The following is a description of a gene set: Human Gene Set: REACTOME_INTERLEUKIN_3_INTERLEUKIN_5_AND_GM_CSF_SIGNALING species: Homo sapiens Interleukin-3, Interleukin-5 and GM-CSF signaling, and this is the list of marker genes: CSF2RA, PIK3R3, PTPN11, RAPGEF1, TEC, VAV1, JAK3, YWHAZ, CRK, INPP5D, UBB, PIK3R2, IL3RA, SYK, IL5RA, PRKACA, CSF2, STAT5A, CSF2RB, SOS1, STAT5B, PIK3CB, HCK, INPPL1, SHC1, IL3, UBA52, IL2, LYN, IL2RA, GAB2, IL5, PIK3CD, FYN, JAK1, BLNK, YES1, UBC, GRB2, RPS27A, JAK2, IL2RG (NCBI Gene Id 3561), CBL, CRKL, IL2RB, PTPN6, PIK3R1, PIK3CA